The following is a description of a gene set: studied in species Homo sapiens Human Gene Set: GAO_LARGE_INTESTINE_24W_C11_PANETH_LIKE_CELL from publication Gao S, Yan L, Wang R, Li J, Yong J, Zhou X, Wei Y, Wu X, Wang X, Fan X, Yan J, Zhi X, Gao Y, Guo H, Jin X, Wang W, Mao Y, Wang F, Wen L, Fu W, Ge H, Qiao J, Tang F (PMID 29802404), and this is the list of marker genes: ZNF267, PLA2G7, NSMAF, NPL, CSF2RB, LINC00996, CFP, CD300A, LAT2, CALHM6, INHBA, HCLS1, CD86, CR1, RSAD2, PLAU, IFNGR1, ACTRT3, GPR34, IKZF1, HLA-DRB1, CXCL9, WDFY2, FCER1G, CCR1, FYB1 (NCBI Gene Id 55458), PRKCB, ARL4C, VPS9D1, SGK1 (NCBI Gene Id 6446), PLXNC1, LCP2, CXCR4, CD53, EIF4A3, TNFSF13B, SLC23A2, LSP1, EVI2B, ADGRG5, PGD, GPR65, LGMN, RAP2B, NAIP, C1QB, RIC1, BIRC3, CHI3L1, CORO7 (coronin 7), KIAA0930, CYRIA, MAF, HLA-DQB1, LCP1, DAB2, CTSC, LST1, SPIC, FES, IGSF6, NUFIP1, SLC15A3, VAV1, HLA-DMA, MERTK, PACC1, IFI30, CD33, GLA, SPPL2A, CCL4, SNX20, C1QA, SLAMF7, CD84 (NCBI Gene Id 8832), RIPOR1, IPMK, IRF8, NLRP3, ARHGDIB, STK26, MFSD1, NINJ1, SIGLEC1, MS4A7, SLA, GGTA1 (glycoprotein alpha-galactosyltransferase 1 (inactive)), LYN, NINJ2, FAM168A, IL10, CCL3, ARRB2, AIF1, TNF, RASGEF1B, CXCL16, SAMSN1 (NCBI Gene Id 64092), RGS19, NCF4, TNFRSF1B, CD180, RNASE6, WIPF1, HCST, GATM, SIGLEC11, NR4A3 (nuclear receptor subfamily 4 group A member 3), INPP5D, CLEC10A, HCK (HCK proto-oncogene, Src family tyrosine kinase), SLCO2B1, PRMT9, TLR2, RIPK2, F13A1, UCP2, ABCG1, CYTH4, APOBEC3A, RAC2, CLEC2B, ADAP2, CSF1R, PLEK, WDFY4, GFRA2, PFKFB3, PELI1, FERMT3, CREG1, MTHFD2, ATF5, CASP1, PLIN2, PIK3AP1, SGPP1 (sphingosine-1-phosphate phosphatase 1), LPCAT1, TSPAN33, ICAM4, CD68, GMFG, PTPRE, HSPA6, NR4A2 (nuclear receptor subfamily 4 group A member 2), IL1R2, SLC37A2, ABI3, ACP5, ITGAM, IL1B, WAKMAR2, NDST2, MANBA, IL1RN, JMY, AOAH, LYVE1, CXCL10, IL1A, LILRB1, IL4I1 (NCBI Gene Id 259307), CSF3R, MAFB, MPEG1, CXCL2, ITGB2, FPR1, CTSL, LYZ, TNFAIP2, PPIF, NCF2, BCL2A1, FCGR1A, GPSM3, TRAF1, HCAR3 (NCBI Gene Id 91492), CD300E, PTGS2, SOD2, CTSZ, PTPRC, FAM110A, DUSP2, CD40, LILRB5, CXCL3 (NCBI Gene Id 2921), CD74, LILRB4, ENSG00000215022, ZNF331, SLC25A37, LPAR6, DOK2, SNN, CD163L1, RHBDF2, CD83, OGFRL1, HLA-DPA1, NCF1, RUBCNL, PLCB2, DNASE1L3, SLAMF8, ST3GAL5, ABCA1, C5AR1, TPP1, MMP9, HCAR2, MS4A4A, RASSF5, HAVCR2, SLC9A9, STAB1, ADCY7, ATP1B3, CLEC7A (C-type lectin domain containing 7A), LIPA, CD209 (CD209 molecule), CD4, EDEM1, CMKLR1, SFMBT2, SRGN, TLR4, SECTM1, KLHDC7B, HLA-DRA, CD48, CNEP1R1, PTAFR, GM2A, STX11, GPR132, EYA2, TFEC, ADCY9, NAMPT, ENSG00000283674, DNAJA4, CD163, BTK, SLFN11, ATP6V1B2, HPGDS, RILPL2, PLCG2, FCGR3A, FCGR2A, HLA-DQA1, IL23A, CEBPB, CYBB, ABRAXAS2, THBD, TYROBP, FLI1, IRS2, ITGAX, PDE4B, LAPTM5 (lysosomal protein transmembrane 5), ADA2, C2, NFKBIE, NCKAP1L, GNPDA1, CD37, NFAM1, SLC7A5, PLAUR, GBP5, COTL1, CXCL8, RNF144B, RUNX3, MARCHF1, METAP1D, FGL2, LILRB2, UAP1L1, SLC8B1, SLC35F6, EBI3, CPVL, CCDC134, UVRAG, ATP11A, TBXAS1, SLC1A4, OSM, DUSP6, HLA-DPB1 (major histocompatibility complex, class II, DP beta 1), ITGB2-AS1, DOCK2, MS4A6A, HLA-DMB, GNL3 (G protein nucleolar 3), METRNL, GPR137B, SNX10, TNFAIP3, ICAM1, CLEC4G, CIMAP1B, WAS, CD14, EOLA1, LMO2, MRC1, LYPD3, NCF1B, FGD2, C1QC, SH2B3, MCOLN1, HMOX1, LY86, FMNL1, KYNU, SPI1